Given this list of marker genes Shh, Tcf7l2, Tcf7, Wnt5a, Dact1, Gli2, Hoxd13, Gli3, Hoxa13, here is a description of the gene set: Mouse Gene Set: GOBP_HINDGUT_MORPHOGENESIS species: Mus musculus The process in which the anatomical structures of the hindgut are generated and organized.